Given this list of marker genes TFAP2A, ARHGAP31, EOGT, HSPA9, BMS1, KCTD1, PLEC, CPLX1, MMP1, PIGG, KRT5, TAF1, MCTP2, ITGB4, LAMA3, UBA2 (ubiquitin like modifier activating enzyme 2), LAMC2, NOTCH1, AHDC1, ALX4, LAMB3, KRAS, ATP6V1B2, COX7B, RBPJ, DOCK6, NSD2, DSP, CDH1 (cadherin 1), UBR1, FGFRL1 (fibroblast growth factor receptor like 1), COL7A1, LETM1, CTBP1, FOSL2, MSX2, ITGA6 (NCBI Gene Id 3655), ZFX, NELFA, KRT14, DLL4, ALG9, COL17A1, here is a description of the gene set: A developmental defect resulting in the congenital absence of skin in multiple or solitary non-inflammatory, well-demarcated, oval or circular ulcers with a diameter of about 1 to 2 cm. Aplasia cutis congenita most commonly occurs on the scalp, but may present in the face, trunk, or limbs. Aplasia cutis congenita Human Gene Set: HP_APLASIA_CUTIS_CONGENITA species: Homo sapiens